The following is a description of a gene set: studied in species Homo sapiens Genes identified as transcriptionally activated by p53 in at least 5 out of 20 genome-wide p53 gene expression profiles and identified as bound by p53 within 2.5kb of the TSS in at least 4 out of 15 genome-wide p53 binding profiles. Genes directly bound and regulated by TP53. Human Gene Set: FISCHER_DIRECT_P53_TARGETS_META_ANALYSIS from publication Fischer M, Grossmann P, Padi M, DeCaprio JA (PMID 27280975), and this is the list of marker genes: FDXR, HHAT, TNFRSF10D, RRAD, GCH1, MBD5, PPP1R3C, LRATD2, MGRN1 (mahogunin ring finger 1), IER3, HRAS, UQCC1, CEL (carboxyl ester lipase), TMEM63B, TMEM68, ZNF337, DCP1B, ANXA4, ABCA12, BAX, GABARAPL2, BHLHE40, EDN2, FLRT2, KRT8, SFXN5, YAP1, SLC30A1, NCEH1, PTP4A1, ARHGAP42, FBN2, BCL2L1, NTPCR, S100A2, RPS27L, PSTPIP2, TRIAP1 (NCBI Gene Id 51499), ISYNA1, ARFGEF2, MON2, NDUFAF8, GASK1B, BCL6, ADIRF, CDH8, IKBIP, TEAD3, KLHL12, DRAM1, REV3L, MUC2, BTG2, BCL9L, SLC12A4, DDB2, RPS19, BLOC1S2, ZNF219, ALDH1A3, PRDM1, CLP1, NUPR1, PBLD, MAP3K12, CSF1, DUSP14, COQ8A, MAST4, DGKA, APAF1, DDR1, TRIM22, TET2, EFNB1, POLH, FAM210B, ANKRA2, CROT, RCBTB1, PRKAB2, PPP4R3A, ZNF79, OBSL1, RRM2B, EPHA2, GDF15, LCE1E, CFLAR, H2BC21, COL7A1, SLC46A1 (NCBI Gene Id 113235), MRPL39, ATF3, XPC, SERPINE1, PRRG2, PTEN, BBC3, BORCS7, STAT3, ASCC3, GNAS, RETSAT, ZNF423, TP53I3, TRIB1, PRKAB1, ZNF561, AK3, CDIP1, HEXIM1, TLCD1, PADI4, ISCU (NCBI Gene Id 91850), DNAI3, FAS, SEMA3B, MRPL49, ARAP1, GSS, TRIP6, VWCE, RGMA, EPM2AIP1, FBXW7, LRP1, GPX1, POU2F2, GNAI1, TRIM35, CDKN1A, NDUFV3, SLC25A45 (NCBI Gene Id 283130), RIN1, SLC4A11, POLR2H, CPSF4, FCHSD2, MLF2, TLR3, EI24, TP53, LINC02875, DYRK3, TNFAIP8, RFK, ETV7, RALGAPB, SERTAD1, TGS1, ACER2, CCNG1, RNF19B, CSNK1G1, LNPEP, WDR81, BLCAP, TSPAN11, BCL10, BRMS1L, TMEM131, SFN, VCAN, MICALL1, TRIM32, APOBEC3H, SESN2, SRA1, KLHDC7A, AEN, SULF2, PHPT1, ZC3HAV1, RABGGTA, PPM1D (NCBI Gene Id 8493), NOPCHAP1, IRF2BPL, ITGA3, TNFRSF10C, PANK1, KRT15, RNF144B, GADD45A, NINJ1 (ninjurin 1), SLC9A1, TRUB1, RAD51C (RAD51 paralog C), SYNC, ORAI3, PRKD2 (protein kinase D2), E2F7, DNAJB5, PARD6B, PDE4C, RAB1A, SNX2, MARF1, USP15, TMEM64, MDM2 (NCBI Gene Id 84825), PHLDA3, SAC3D1, AGBL5, RGL1, STX6, EDA2R, TCAIM, MARCHF8, GRHL3, KIAA1217, CAVIN2, MFAP3L, AKAP9, HES1, SYTL1, CMBL, LMNA, SCN2A, CNOT6, LPXN, NKAIN4, PLK2, ZNF385A, GPC1, PLK3, PLXNB2, TIGAR, CLCA2, TXNIP, CYSRT1, MFGE8, CPEB2, GREB1, PIDD1, COBLL1, EID2B, SERPINB5, ZNF564 (zinc finger protein 564), APOD, PMAIP1, POU3F1, TNFRSF10A, GPR87, TMEM243, LIMA1, GBE1, ITPKC, EFCAB10, NEFL, IER5, LIF, PML, KCNN4, UTP3, TP53INP1, FCHO2, ACTA2, CDC42SE1, CD82, IGDCC4, SARS1, SPATA18, CHST14, TYMSOS, HSPA4L, TM7SF3, ASTN2, CCDC90B, NADSYN1, RGS16, EPS8L2, NHLH2 (nescient helix-loop-helix 2), BTBD10, SCRIB, MCC, FAM98C, CYFIP2, TUBB6, FBXO22, INKA2, APOBEC3C (NCBI Gene Id 91578), SMAD5, BTG1, KCTD1, LRPAP1, RAP2B, DHRS3, SMAD3, ZNF37A, ABCB6, SESN1, SOCS4, TNFRSF10B, ICOSLG, SUPT7L, SUSD6, F5, PPFIBP1, TSKU, BBS2, PARD6G, PCNA, EML2, IGFBP7, TANC1, TRAF4, ZMAT3, TEPSIN, AMZ2, NYNRIN